Given this list of marker genes Acsl4, Cyp7a1, Tm7sf2, Srebf2, Abca1, Sqle, Mylip, Sc5d, Fdft1, Nr1h3, Cyp51, Scd2, Pmvk, Nsdhl, Elovl5, Idi2, Hsd17b7, Hmgcs1, Soat2 (NCBI Gene Id 28073), Srebf1, Cyp27a1, Hmgcs2, Msmo1 (methylsterol monoxygenase 1), Fdps, Acsl3, Cyp46a1, Elovl2, Idi1, Fads2, Acot2, Abcg1, Nr1h2, Acsl1, Scd1, Lbr, Fasn, Mvk, Soat1, Acat2, Ch25h, Dhcr24, Dhcr7, Elovl4 (ELOVL fatty acid elongase 4), Lss, Mvd, Ebp, Fads1 (NCBI Gene Id 77186), Acot1, Ggps1, Elovl3, Hmgcr, Acat1, here is a description of the gene set: studied in species Mus musculus Mouse Gene Set: WP_CHOLESTEROL_METABOLISM_WITH_BLOCH_AND_KANDUTSCHRUSSELL_PATHWAYS Cholesterol metabolism with Bloch and Kandutsch-Russell pathways